The following is a description of a gene set: Human Gene Set: GSE7460_CTRL_VS_TGFB_TREATED_ACT_TCONV_DN Genes down-regulated in comparsion of ActCD4 versus ActCD4TGF (see Fig. 1 in the paper for details). The transcription factor Foxp3 is usually considered the master regulator for the CD4+CD25+ from publication Hill JA, Feuerer M, Tash K, Haxhinasto S, Perez J, Melamed R, Mathis D, Benoist C (PMID 18024188) species: Homo sapiens, and this is the list of marker genes: IER5, CAMKMT, MTERF1, ZCCHC24, PLEKHD1, ATP1A2, HSD3B7, DYNLRB1, RAB20, RTF2, GRK4, H19, DIAPH2, KCNK6, NMNAT1, CDH13, SPECC1, RAB3IP, STAT3, ATRN, ACVR2B, DOCK4, MAPKAPK3, SMAD7, BIN1, LGALS9B, CHD9, CASD1, DEDD, MMP11, B4GALT7, CPD, VCAN, ADGRG3, IGHG1, MYL9, MED10, TTC39B, WBP1, AADAT, CERK (NCBI Gene Id 64781), NCMAP, GBA1, IRF4, FURIN, ZNF277, COL22A1, KRAS, RPLP0, TRADD, ZFP1, ACCS, SPATA13, TNFRSF13C, INPP5D, TREML2, ELL2, HEPACAM2, ADAMTS6, AQP3, ARRDC4, SDCCAG8, CNIH3, CNPY2, IRF2BP2, CD38, TLE3, ACVR1C (activin A receptor type 1C), SUOX, PISD, GEM, NIBAN2 (NCBI Gene Id 64855), LYN, GOLM1, AHRR, NTAQ1, ATOSB, CIB1, RANBP6, STIM2, AMOT (NCBI Gene Id 23340), MXD1, IFITM3, NCF1, VASP, ODR4, PREPL, NINJ1, SLC17A9, RHOH, TEAD1, DUSP2, FCHSD2, GLIPR1L1, SYCP2L, PAIP1, FOXP3, DSTN, POLM, TUBGCP4, ATG10, IGFBP4, B4GALNT4, ATP6V0D1, SMURF2, PTPRJ, ACSBG1, IKZF4, TAX1BP3, CAMK2N1, CYP1B1, SKIL, STK38L, AHR, MCCC1, NIN, NRARP, GFOD1, ABI3, ADPGK, GPHN, NRP1, SPSB1, TMEM199, CD40, AP1M2, THY1, P2RY1, RAMP1, ABHD15, EEF1AKMT1, GLT8D2, RUFY3, CAMK2D, RGS1 (regulator of G protein signaling 1), TULP4, PPM1L, RHOB, NEK7, COMMD7, CD37, TCF4, ST8SIA1, CD8A, TRAF4, IFITM2, FGL2, ZBTB18, STON1, WDR17, UBE2F, SLC44A1, LRIG1, GOLM2, PMEPA1, CFTR, ENDOD1, ANKRD50, C19orf12 (NCBI Gene Id 83636), NLRP6, NIPAL1, TBC1D14, IFT88, ACTR3B, KIT, SESTD1, MGAT5, FMNL3, ENTPD1, BMPR2, UBLCP1, TMEM230, UBXN11, NCF4, MYADM, ARSB, FKBP15, ENDOV, SH3GL1, RNF149, ATP6AP1, ATP6V1G2, BEND4, FAM241A, FKBPL, PPIB, TGFBR1, TRIP4, MYRIP, SYNGR2, LPXN, NT5E, RHOF, TRAPPC14, NFAT5, TBC1D16, ITGAE, IFITM5, CTSW, TNFSF10